Given this list of marker genes CCNB1, KIFC1, CDC20 (cell division cycle 20), CENPF, CCNA2, CKS2, KNL1, CDKN3, KIF2C, SPAG5, here is a description of the gene set: Genes down-regulated in response to nutlin-3a, an inhibitor of MDM2, in skin fibroblast cultures after knockdown of TP53 by RNAi. studied in species Homo sapiens Human Gene Set: KUMAMOTO_RESPONSE_TO_NUTLIN_3A_DN Nutlin-3, an MDM2 inhibitor, activates p53, resulting in several types of cancer cells undergoing apoptosis. Although p53 is mutated or deleted in approximately 50% of all cancers, p53 is still functionally active in the other 50%. Consequently, nutlin-3 and similar drugs could be candidates for neoadjuvant therapy in cancers with a functional p53. Cellular senescence is also a phenotype induced by p53 activation and plays a critical role in protecting against tumor development. In this report, we found that nutlin-3a can induce senescence in normal human fibroblasts. Nutlin-3a activated and repressed a large number of p53-dependent genes, including those encoding microRNAs. mir-34a, mir-34b, and mir-34c, which have recently been shown to be downstream effectors of p53-mediated senescence, were up-regulated, and inhibitor of growth 2 (ING2) expression was suppressed by nutlin-3a treatment. Two candidates for a p53-DNA binding consensus sequence were found in the ING2 promoter regulatory region; thus, we performed chromatin immunoprecipitation and electrophoretic mobility shift assays and confirmed p53 binding directly to those sites. In addition, the luciferase activity of a construct containing the ING2 regulatory region was repressed after p53 activation. Antisense knockdown of ING2 induces p53-independent senescence, whereas overexpression of ING2 induces p53-dependent senescence. Taken together, we conclude that nutlin-3a induces senescence through p53 activation in normal human fibroblasts, and p53-mediated mir34a, mir34b, and mir34c up-regulation and ING2 down-regulation may be involved in the senescence pathway. from publication Kumamoto K, Spillare EA, Fujita K, Horikawa I, Yamashita T, Appella E, Nagashima M, Takenoshita S, Yokota J, Harris CC (PMID 18451145)